Given this list of marker genes CIB2, RIPOR2, MPP1, STRC, CABP1, KCNQ4, CDH23, CAPZB (NCBI Gene Id 832), TMC2, CTBP2, MYO15A, TMIE, CACNB2, SPTAN1, TMC1, GRXCR2, EPB41L3, TRIOBP, CAPZA1, TWF2 (twinfilin actin binding protein 2), CACNA2D2, SLC26A5, KCNN2, EPS8L2, PCDH15, EPB41L1, ATP2B2, LRRC52, ACTB, CHRNA9, SYP, GSN, SLC17A8, USH1C, BSN, KCNMA1, ESPNL, KCNMB1, PLS1, MYO3B, SNAP25, OTOGL, OTOG, XIRP2, EPS8, CHRNA10, MYO1C, CABP2 (calcium binding protein 2), RDX, USH1G (USH1 protein network component sans), PJVK, FSCN2, CACNA1D, VAMP2, LHFPL5, CLIC5, CASK, MYO3A (myosin IIIA), MYH9, DNAJC5, ESPN, ACTG1, OTOF, CAPZA2, EZR, SPTBN1 (spectrin beta, non-erythrocytic 1), TWF1, MSN, WHRN, STX1A, MYO7A, PCLO, RAB3A, TPRN, ATP2B1, GRXCR1 (glutaredoxin and cysteine rich domain containing 1), SYN1, here is a description of the gene set: species: Homo sapiens part of: Sensory Perception In mammals, sounds are processed in the cochlea, a spiral-shaped organ in the inner ear. Low frequency sounds are sensed at the distal end (apex) of the cochlea; high frequency sounds are sensed at the proximal end (base) of the cochlea. Sound vibrations are transmitted from the eardrum through the three bones of the inner ear (malleus, incus, stapes) and the oval window of the cochlea to the fluids within the cochlea. Within the organ of Corti in the cochlea there are 3 rows of outer hair cells (OHCs) on the external side of the tunnel of Corti and 1 row of inner hair cells (IHCs) on the internal side. Each IHC synapses with approximately 20 afferent myelinated type I spiral ganglion neurons and functions as a sensory receptor to convert the energy of sound waves to secretion of glutamate neurotransmitter. Multiple OHCs synapse with each unmyelinated type II afferent neuron and OHCs are also synapsed with efferent medial olivocochlear fibers. The primary function of OHCs, however, is amplification of organ of Corti motions in response to sound. Amplification is produced by changes in receptor-potential driven cell length caused by changes in the conformation of the unusual membrane protein prestin (SLC26A5, Zheng et al. 2000).<br>IHCs and OHCs sense the sonic vibrations by deflection of stereocilia on their apical surfaces. The stereocilia are arranged in rows of increasing height, with a stereocilium of one row connected to a stereocilium of another row by a tip link composed of a CDH23 dimer on the taller stereocilium joined at its N-termini to the N-termini of a PCDH15 dimer on the shorter stereocilium. CDH23 is connected to the cytoskeleton of the taller stereocilium via MYO7A (MyoVIIa), USH1C (Harmonin), and USH1G (Sans) while PCDH15 on the shorter stereocilium interacts with LHFPL5, an auxiliary subunit of the mechanoelectrical transduction channel (MET channel, also known as the mechanotransduction channel), which contains at least TMC1 or TMC2, TMIE, and the auxiliary subunits LHFPL5 and CIB2. Deflection of stereocilia in the direction that increases tension on the tip link causes depolarization of the cell by increasing the open probability of the MET channel, which then transports calcium and potassium into the hair cell according to the gradient of those ions between the scala media (containing endolymph at 154 mM K+ and <1 mM Ca2+) at the apex of the cell and the scala tympani (containing perilymph at 7 mM K+) at the base. Similarly, compression of the tip link by deflection of the stereocilia in the opposite direction decreases the open probability of the MET channel and causes hyperpolarization of the cell.<br>Depolarization of IHCs causes opening of voltage-gated calcium channels arrayed in stripes on the basolateral membrane close to ribbon synapses formed between the IHC and the afferent fiber of a myelinated type I spiral ganglion neuron. This results in a localized increase in cytosolic calcium ions which interact with Otoferlin (OTOF) on glutamate-containing synaptic vesicles at the ribbon structure to activate exocytosis of glutamate into the synapse formed with the afferent neuron. Ribbon synapses are distinguished by electron-dense ribbon structures projecting from the presynaptic membrane into the cytosol and comprising at least BASSOON, RIBEYE (an isoform of CTBP2), and PICCOLINO (an isoform of PICCOLO). The ribbon structures appear to transiently bind synaptic vesicles and facilitate resupply of synaptic vesicles at active zones to refill the pool of readily releasable vesicles.<br>In contrast with IHCs, OHCs mainly function in sound amplification by decreasing up to about 4% in length in response to depolarization caused by opening of the MET channel and increasing in length in response to hyperpolarization caused by channel closing, resulting in alternating compression and decompression between the reticular lamina and the basilar membrane. The changes in the length of the OHC are caused by very rapid (microseconds), voltage-sensitive changes in the conformation of the membrane protein prestin (SLC26A5). Stereociliary ATP2B2 (PMCA2) extrudes calcium ions and basally located KCNQ4 extrudes potassium ions to repolarize the OHC.<br>OHCs are synapsed with efferent cholinergic medial olivocochlear fibers. Acetylcholine released at the synapse binds an unusual, nicotine-antagonized, nicotinic receptor comprising CHRNA9 and CHRNA10. Upon binding acetylcholine, CHRNA9:CHRNA10 transports calcium ions into the OHC. The calcium activates SK2 potassium channels (KCNN2) and BK potassium channels (KCNMA1:KCNMB1) which extrude potassium ions, hyperpolarize the OHC, and inhibit activation of the OHC.<br> Loud sounds can cause a temporary threshold shift (temporary loss of hearing) caused by damage to stereocilia and synapses or permanent threshold shift (permanent loss of hearing) caused by damage or death of hair cells and neurons. Reactome Pathway: Sensory processing of sound